The following is a description of a gene set: from publication Busslinger GA, Weusten BLA, Bogte A, Begthel H, Brosens LAA, Clevers H (PMID 33691112) studied in species Homo sapiens Human Gene Set: BUSSLINGER_GASTRIC_D_CELLS, and this is the list of marker genes: PAX6, CELF4, ERO1B, TM4SF4, SHISAL2B (NCBI Gene Id 100132916), ISL1, IGFBP5, TTN, TMEM176B, SCG5, NEUROD1, NR4A1, MS4A8, DEPP1, SEC11C, CHGB, CEP126, TPPP3, CAMK2B, MAP1B, PCSK2, KCTD12, ARFGEF3, EGR1, CADM1, PCSK1N, SST, TTR